Given this list of marker genes C5AR1, VAV3, CXADR, RAC2, CXCL10, PIK3CG (NCBI Gene Id 5294), PIK3CD, C1QBP, EDN3, CAMK1D (calcium/calmodulin dependent protein kinase ID), LGALS3, CXCL5, SLIT2, S100A8, S100A12, THBS4, C3AR1, VAV1, TGFB2, ITGA1, DAPK2, JAML, EDN2, TIRAP, CXCL8, PIKFYVE, PPIA, CKLF, CCL21, CXCR1, FCER1G, PPBP, TNFAIP6, BST1, RIPOR2, MCU, BSG, IL23A, LBP, PREX1, CD74, MDK, CCL28, CX3CL1, CD300H, S100A9, PF4V1, JAM3, MIR223, ITGB2, DPP4, PPIB, RAC1, PIP5K1C, SAA1, CXCL9, EDN1, MOSPD2, PDE4B, CSF3R, NCKAP1L, PLA2G1B, CXCL13, CCL19, DNM1L, CXCR2, SYK, ITGA9, PF4, CCR7, MPP1, GBF1, IL1B, CXCL6 (NCBI Gene Id 6372), XCL1, PERP, TREM1, SRP54, CXCL3, DPEP1, C5AR2, CCL27, CCL3, here is a description of the gene set: The directed movement of a neutrophil cell, the most numerous polymorphonuclear leukocyte found in the blood, in response to an external stimulus, usually an infection or wounding. studied in species Homo sapiens Human Gene Set: GOBP_NEUTROPHIL_CHEMOTAXIS